Given this list of marker genes Pcbd1, Lgals1, Hao2, Sdhd, Hsd17b10, Serinc1, Mcee, Glul, Suclg1, Ppara, Aoc3, Fabp1, Cbr1, Gcdh, Aldoa, Dlst, Auh, Elovl5, Adsl, Fabp2, Ncaph2, Rdh11, Prdx6, Blvra, Hmgcs1, Hsph1, Acadm, Acox1, Nsdhl, Acot2, Cryz, Ephx1, Cel, Rap1gds1, Sdha, S100a10, Acss1, Hpgd, Gabarapl1, Ywhah, Car4, Slc22a5, Car2, Bphl, Hsd17b4, Mlycd, Odc1, Bckdhb, Hccs, Acat2, Ostc, Cpt2, Bmpr1b, Acaa2, Cpt1a, Eno3, Ugdh, Acsl5, Etfdh, Fasn, Cbr3, Inmt, Eno2, Idh3g, Idh3b, Acot8, Car6, Ech1, Mgll, Mif, Mdh1, Trp53inp2, Fh1, Hadhb, Aadat, Grhpr, Metap1, Vnn1, Hmgcs2, Cyp4a10 (cytochrome P450, family 4, subfamily a, polypeptide 10), Uros, Gad2, Urod, Ptprg, Aldh9a1, Echs1 (NCBI Gene Id 97386), Me1, Aldh1a1, Sucla2, D2hgdh (NCBI Gene Id 98314), Gapdhs, Eci2, Cidea, Sdhc, Reep6, Adh7, Maoa, Ltc4s, G0s2, Tdo2 (NCBI Gene Id 99471), Hibch, Pts, Adipor2, Hsd17b11, Acaa1a, Aldh3a1, Crat, Cd36, Nthl1, Gpd1, Acsl4, Mix23, Hsp90aa1, H2az1 (H2A.Z variant histone 1), Acadvl, Cyp1a1, Xist, Cd1d2, Gpd2, Aco2, Hsdl2, Hadh, Gstz1, Alad, Acadl, Ehhadh, Cpox, Decr1 (NCBI Gene Id 67460), Ldha, Aldh3a2, Hmgcl, Hsd17b7 (hydroxysteroid (17-beta) dehydrogenase 7), Retsat (retinol saturase (all trans retinol 13,14 reductase)), Acsm3, Pdha1, Aqp7, Rdh1, Kmt5a, Mdh2, Dhcr24, Ube2l6, Psme1, Idh1, Suclg2, Acads, Nbn, Idi1, Apex1, Erp29, Eci1, Sms-ps, Dld, Fmo1, Pdhb, Acsl1, here is a description of the gene set: Mouse Gene Set: HALLMARK_FATTY_ACID_METABOLISM Mouse genes annotated to HALLMARK_FATTY_ACID_METABOLISM based on orthology mappings provided by the Alliance Genome Consortium from publication Howe DG, Blake JA, Bradford YM, Bult CJ, Calvi BR, Engel SR, Kadin JA, Kaufman TC, Kishore R, Laulederkind SJF, Lewis SE, Moxon SAT, Richardson JE, Smith C (PMID 30224793) species: Mus musculus